The following is a description of a gene set: from publication He P, Lim K, Sun D, Pett JP, Jeng Q, Polanski K, Dong Z, Bolt L, Richardson L, Mamanova L, Dabrowska M, Wilbrey-Clark A, Madissoon E, Tuong ZK, Dann E, Suo C, Goh I, Yoshida M, Nikolić MZ, Janes SM, He X, Barker RA, Teichmann SA, Marioni JC, Meyer KB, Rawlins EL (PMID 36493756) Human Gene Set: HE_LIM_SUN_FETAL_LUNG_C3_HMOX1_POS_PRIMITIVE_ERYTHROBLAST studied in species Homo sapiens HMOX1+ primitive erythroblast, and this is the list of marker genes: SMIM5, GFI1B, FDXR, MT1F, GRAP2, MT1H, MTURN, AEN (apoptosis enhancing nuclease), YPEL4, UCA1, SLC39A8, HBZ, TMOD1, KLF1, HMOX1, GDF15, ICAM4, H2BC11, CDKN1A, HBE1 (hemoglobin subunit epsilon 1), MT1X, PPP1R14C, MT1G, ACSM3, S100A4 (S100 calcium binding protein A4)